Given this list of marker genes DHX33, NUMA1, KANSL1, NKX2-5, SLC13A4, GPM6A (NCBI Gene Id 2823), TSPAN4, CBLN2, SEMA3E, BICC1, PCDHB13, WDFY4, ANKRD63, DUSP18, MESP2, RASSF9, MROH1, FAM178B, BRAP, PIEZO2, PIWIL1, C5orf52, DXO, DDR2, DPEP1, MALL (mal, T cell differentiation protein like), TMEM229A, MCF2, FUT9, ZFP30, PRDM14, FOSL1, ARHGAP23, ZNF513, APOD, COPZ2, VTN, KCNG1, LGI3, SOX10, HOXA3, OTULINL, JAKMIP3, LTB4R2, USP49, MC3R, FANK1, KRT81, MIR99AHG (NCBI Gene Id 54079), MTIF3, PDE6B, GNAL, ATOH1, FBXL16, MUC16, PLAGL1, TCAP, CSF2RB, TRIM10, PALM, DGKD, TCTE1, PROCA1, CNTNAP4 (NCBI Gene Id 85445), GGT6, KRT4, MYOZ1, RGN, RSPH4A, SRMS, ATG4C, CAVIN1, FBXO42, NTMT1, PHAF1, WFDC2, RIN3, RASL10B, TRPC7, RNF32, DAB1, MED23, FBLIM1, KBTBD13 (kelch repeat and BTB domain containing 13), TYR, DUSP9, FAM20C (FAM20C golgi associated secretory pathway kinase), ALPK3, CALHM4, PDE6A, MISFA, RGMB, RASSF6, DYNC1H1, DLX2, SLC6A16, ADAMTSL3, FCRLA, TMEM116, CDHR4, OSBP, ST8SIA2, CACNA1C, AIF1L, APPL2, DNAH9, SLC34A3, C19orf81, CCNT1, SLC26A11, PRRC2A (NCBI Gene Id 7916, proline rich coiled-coil 2A), POU3F4, TERB2, ZNF790, FAM3B (NCBI Gene Id 54097), LIMS2 (LIM zinc finger domain containing 2), CNTN2, NFATC4, ARHGAP45, EPHA3, DCTN1, CFAP299, ADCYAP1, N4BP2L1, FARP1, GRAMD1A, C19orf18, TWIST2, BTG4, CCL4, MERTK, LDB1, CRB3, MSL1, SLC4A4, MYOD1, UTS2R, ZBTB7B, BRSK2, HCN2, SLITRK6, LGR5, CD5L, AHNAK2, AP2A2 (NCBI Gene Id 25955), PNPLA3, TRIM71, NAA11, SCN4B, ANKEF1, SNHG11 (small nucleolar RNA host gene 11), OPRK1, MTARC1, MAT2B, NDUFA4L2 (NDUFA4 mitochondrial complex associated like 2), MCAM, FRS3, TFAP2D, FCHSD1, ADAMTS19, KHDRBS2, NAPB, SASH3, VXN, DLGAP1, ENPEP, LMLN, FCER2, TMEM238L, ATP8B3, SCN7A, FGF10, ZNF646, SHMT1, NDST2, MKNK2, KIF13A, BET1L, CUL4A, SIX4, GPR179, FBLN5, CAVIN3, PRAMEF2, ENTREP2, PRRG1, MAP4K4, FMO2, SLC17A6, ST6GALNAC3, DTX2, CBFA2T2, SEPTIN3, GRIN2D, DCDC2B, PEX5L, TTYH2, DLL1, CCT8L2, CD28, here is a description of the gene set: species: Homo sapiens from publication Durant L, Watford WT, Ramos HL, Laurence A, Vahedi G, Wei L, Takahashi H, Sun HW, Kanno Y, Powrie F, O'Shea JJ (PMID 20493732) Human Gene Set: GSE21670_TGFB_VS_IL6_TREATED_CD4_TCELL_UP Genes up-regulated in CD4 T cells: TGF beta versus IL6. STAT3, an essential transcription factor with pleiotropic functions, plays critical roles in the pathogenesis of autoimmunity. Despite recent data linking STAT3 with inflammatory bowel disease, exactly how it contributes to chronic intestinal inflammation is not known. Using a T cell transfer model of colitis we found that STAT3 expression in T cells was essential for the induction of both colitis and systemic inflammation. STAT3 was critical in modulating the balance of T helper 17 (Th17) and regulatory T (Treg) cells, as well as in promoting CD4+ T cell proliferation. We used chromatin immunoprecipitation and massive parallel sequencing (ChIP-Seq) to define the genome-wide targets of STAT3 in CD4+ T cells. We found that STAT3 bound to multiple genes involved in Th17 cell differentiation, cell activation, proliferation and survival, regulating both expression and epigenetic modifications. Thus, STAT3 orchestrates multiple critical aspects of T cell function in inflammation and homeostasis.